Given this list of marker genes BAZ2A, TTC39A, ZZEF1, CTDSPL, KBTBD8 (NCBI Gene Id 84541), HS3ST3B1, TRIB2, FGFR3, ETFDH, PCSK9, ATP11C, FZD8, SMARCA5, HS3ST2, MTOR, RAVER2, NOX4, NR6A1, here is a description of the gene set: Genes predicted to be targets of miRBase v22 microRNA hsa-miR-100-5p, hsa-miR-99a-5p, hsa-miR-99b-5p in miRDB v6.0 with MirTarget v4 prediction scores > 80 (high confidence targets). Human Gene Set: MIR100_5P_MIR99A_5P_MIR99B_5P from publication Chen Y, Wang X (PMID 31504780) species: Homo sapiens